The following is a description of a gene set: Human Gene Set: chr2p23 studied in species Homo sapiens, and this is the list of marker genes: TOGARAM2, SUPT7L (NCBI Gene Id 9913), SF3B6 (NCBI Gene Id 51639), SLC30A3, PGAM1P6, UCN, PLB1, ENSG00000251805, YPEL5, RPL37P11, ZNF512, EHD3, PPIL1P1, LINC01381, PCARE, RNA5SP90, RPS2P15, CENPA, RPS13P5, ASXL2, RNU6-370P, HMGN2P20, DNAJC27-AS1, TMEM214, DNMT3A, SNORA10B, OST4, RPS13P4, CIMIP2C, ENSG00000230737, ITSN2, GCKR, FKBP1B, RPL21P70, RNU6-942P, H3P5, LCLAT1, MIR4263, ABHD1, RNA5SP89, DTNB-AS1, NCOA1 (NCBI Gene Id 8648), CAPN14, KCNK3, RNU6-936P, HADHA, ZNF513, ADCY3, AGBL5, XDH, PTRHD1, PFN4, RBKS, ADGRF3, EMP2P1, FNDC4, FTH1P3 (NCBI Gene Id 90651), SNX17, PPP1CB-DT, RPL36AP13, GTF3C2-AS1, RNA5SP88, SNORD53, SLC5A6, DNAJC5G, DRC1, SLC35F6, RPL23AP34, TRIM54, UQCRHP2, RN7SL610P, IFT172, KHK, TRMT112P6, RAB10, LINC01936, SRD5A2, OTOF, ATAD2B, NRBP1, GALNT14, EMILIN1, FAM133EP, SNORD53B, HADHB, ALK, RNU6-986P, MAPRE3-AS1 (MAPRE3 antisense RNA 1), TP53I3, ARNILA, MAPRE3, DNAJC27, SELENOI, LINC01460, FOSL2-AS1, ATRAID, AGBL5-AS1, FAM228B, SNRPGP7, FOSL2, UBXN2A, MIR1301, SPATA31H1, EFR3B, DTNB, SNORD92, RN7SL856P, GAREM2, MRPL33, GTF3C2, CLIP4, PREB, CIB4, EIF2B4, CGREF1, NDUFB4P4, SPDYA (NCBI Gene Id 245711), WDR43, RN7SL516P, CENPO, CDKN2AIPNLP2, CCDC121, KRTCAP3, SMARCE1P6, PRR30, MFSD2B, KIF3C, PPP1CB, TCF23 (transcription factor 23), AGBL5-IT1, ENSG00000206731, DPYSL5, PTGES3P2, LBH, FAM228A, MPV17, GTF3C2-AS2 (NCBI Gene Id 105374363), TRMT61B, PPM1G, GPN1, CAD, MYG1P1, SDHCP3, BABAM2, CAPN13, TPM3P7, SUCLA2P3, SLC4A1AP, WDCP, POMC